Given this list of marker genes SOX5, RTP4, IL5RA, ABRA (NCBI Gene Id 137735), SLC22A25, STX7, BRD4, MIP, ASB12, IPO13 (importin 13), NEK4, SPP1, EMCN, LY6S, GPR68, PPFIA2, ARRB2, TMC5, RINL, HOXB5, IGF2R, OVOL1, GRIPAP1, SLC29A3, TRRAP, EFEMP1, EDN1, MCTP2, LYNX1 (Ly6/neurotoxin 1), MMD (monocyte to macrophage differentiation associated), NLE1, RASGEF1B, TTC39B, MCCC1, FDPS, YEATS2, SPINK6, PTAFR, DUSP10, IMP4, GAPT, SUPT3H, RORB (RAR related orphan receptor B), HEPACAM2 (NCBI Gene Id 253012), E2F1, ARHGEF28, ARNT, KYNU, GAS5, TRAPPC12, GALNT18, PDILT, REL, RAB3IL1, LY6D, ALOX5AP, PLPP1, CD40 (NCBI Gene Id 958), MITF (melanocyte inducing transcription factor), STOX2, CENPM, ARHGAP35, PGM2, MIR365B, WT1-AS, H2AC1, OAS2, HECTD3, GSAP, CORO2A, LRRK2, MGAT5, TXNDC5, ASB2, EPS15L1, AMELX, PRSS48, FBXO48, DUSP18, SLC39A5, CD180, BGLAP, MST1, NAB1, CD177, CLCA4 (NCBI Gene Id 22802), MED20, PRSS53, RING1, CEBPA, AIRN, XRN1, HS6ST2, PROX2, FKBP2, ANO5, CRB1, SLC1A5, ATG12, AP2A1, TNS3, FOXI3, ERCC6L, SPZ1, ABCG1, COLQ, PRDX2, CARMIL1, DENND2C, SEMA5A, INPP4A, RET, NOS1AP, CALR, CACNA1E, ZC3H12C, EPS8L1, SYT2, REPIN1, EXT1, PPP2R1A, EFCAB7, GUCA1B, CCL28, HOMEZ, SLC5A11, KMO, MIR382, FGF7, OAS3, HSPB9, SLFN5, FBXO34, here is a description of the gene set: Human Gene Set: GSE25677_MPL_VS_MPL_AND_R848_STIM_BCELL_DN studied in species Homo sapiens from publication Kasturi SP, Skountzou I, Albrecht RA, Koutsonanos D, Hua T, Nakaya HI, Ravindran R, Stewart S, Alam M, Kwissa M, Villinger F, Murthy N, Steel J, Jacob J, Hogan RJ, García-Sastre A, Compans R, Pulendran B (PMID 21350488) Many successful vaccines induce persistent antibody responses that can last a lifetime. The mechanisms by which they do so remain unclear, but emerging evidence suggests that activate dendritic cells (DCs) via Toll-like receptors (TLRs). For example, the yellow fever vaccine YF-17D, one of the most successful empiric vaccines ever developed, activates DCs via multiple TLRs to stimulate pro-inflammatory cytokines. Triggering specific combinations of TLRs in DCs can induce synergistic production of cytokines, which results in enhanced T cell responses, but its impact on antibody responses remain unknown. Learning the critical parameters of innate immunity that programs such antibody responses remains a major challenge in vaccinology. We demonstrated that immunization of mice with synthetic nanoparticles containing antigens plus Toll-like receptor (TLR) ligands 4 (MPL) + 7 (R837) induces synergistic increases in antigen-specific, neutralizing antibodies compared to immunization with a single TLR ligand. To determine whether there was any early programming of B cells, we isolated isotype switched, TCRbeta-CD11b-CD19+IgD-IgG+ B cells by FACS at 7 days post immunization with nanoparticles containing various adjuvants plus OVA, and performed microarray analyses to assess their molecular signatures. Genes down-regulated in B lymphocytes immunized with: monophosphoryl lipid A (MPL) versus MPL and imiquimod.